Given this list of marker genes TSC2, IFNG, FOXJ1, SMARCC1, KDM4B, BICRA, TSC1, DLG5, here is a description of the gene set: A form of hydrocephalus in which the flow of cerebrospinal fluid (CSF) within the cerebral ventricular system or in the outlets of the CSF to the arachnoid space is obstructed. Noncommunicating hydrocephalus studied in species Homo sapiens Human Gene Set: HP_NONCOMMUNICATING_HYDROCEPHALUS